Given this list of marker genes PLEKHM3, FBXO36, IGLL1, IL10RB, KLHL26, TMEM213, AGPAT1, RNF166, ACHE, ZNF385C, SLC22A18, TLE6, ZNF865, RPL22L1, RPL7, AJAP1, RAD52, BBX, AQP12A, IGSF9B, SCT, DACH1, ADCY2, MACROH2A1, ATP5MC2, SOBP, ZBTB39, SUB1, HPX, TMEM25, MPPED1, ELAC1, ZBTB8OS, C1QTNF12, CARD6, ZKSCAN5, CLIP4, ZNF260, COL25A1, RAB11FIP1, C8orf33, ALB, ALOX5, MROH2A, NCS1, SCML4, FAHD2A, STAMBP, CARMIL2, STX8, C12orf57, FHIT, DBNDD2, GPBP1L1, SLFN12L, SATB1, TBXA2R, DUSP8, TXNIP, UBN1, KRT81, PTPRF, SYT12, INPP1, PAQR7, ANKZF1, PLXNA3, TRPM6, LMNTD1, SDHC, NSFL1C, CD84 (CD84 molecule), CLCN7, DENND1A, COPZ1, EPS8L3, PTBP1, RPL31, NTRK2, TTLL7, MRPS34, ZNF335, CCNL2, HR, NFE2L1, CAPN13, KCNMA1, SCRT1, RAB37, RAP1GAP, ZNF394, ZNF692, MMEL1, MYBPC3, SERPINA12 (NCBI Gene Id 145264, serpin family A member 12), FAM167B, DLGAP4, KCNJ11, NFE2L3, TCF7, EVL, NUP210L, LPP-AS2, CXorf38, FCGR1A, TMEM151B, CD53, KLF1, TREML2, APOBR, RTL8C, RPL36A, RPS6KA1, SYNE2, NDRG3, GIMAP4, FLOT1, SNRPD1, C9orf50, RGS9, ATG13, RREB1, LAMTOR2, PAQR8, DLX3, ATXN7L3B, RPS14 (ribosomal protein S14), GRAP, HGH1, PHF21A, ALDH1L1, KLK8, TCP11L2, RNF138, TBC1D12, NOBOX, EEF1G (NCBI Gene Id 1937), TMEM204, LTB, AKAP9, CD27, CENATAC, TRIM39, TWNK, AP4S1, CIMIP1, MDM4, GTSF1L, DNASE1L2, ANK1, TCF7L1, SLC2A5 (solute carrier family 2 member 5), NOTCH3, ZSWIM5, RASL11A, MS4A15, FREY1, CLEC4F, IKBKE, ZNF777, RPL18A, GPANK1, NTN5, LRRC61 (NCBI Gene Id 65999), ASPHD1, GREB1, SEZ6L2, CBX7, CACNG5, WFDC5, DDR1, RPL35, ZNF687, ITPR2, LYPD6B, CPNE6, SON (SON DNA and RNA binding protein), AIRN, NCKIPSD, AP5S1, DACT2, TNFRSF1A, GPX7, CLEC16A, ARHGAP28, RTN4R, BAHCC1, CCND2, OLR1, SLC6A3, COX20, MEGF11, RUNDC1, CTRC, PSME1, KRT78, UQCR10, COTL1, ADAM33, here is a description of the gene set: studied in species Homo sapiens Using killer cell lectin-like receptor G1 as a marker to distinguish terminal effector cells from memory precursors, we found that despite their diverse cell fates both subsets possessed remarkably similar gene expression profiles and functioned as equally potent killer cells. However, only the memory precursors were capable of making IL-2 thus defining a novel effector cell that was cytotoxic, expressed granzyme B, and produced inflammatory cytokines in addition to IL-2. This effector population then differentiated into long-lived protective memory T cells capable of self-renewal and rapid re-call responses. Mechanistic studies showed that cells that continued to receive antigenic stimulation during the later stages of infection were more likely to become terminal effectors. Importantly, curtailing antigenic stimulation towards the tail-end of the acute infection enhanced the generation of memory cells. These studies support the decreasing potential model of memory differentiation and show that the duration of antigenic stimulation is a critical regulator of memory formation Human Gene Set: GSE10239_MEMORY_VS_KLRG1HIGH_EFF_CD8_TCELL_UP from publication Sarkar S, Kalia V, Haining WN, Konieczny BT, Subramaniam S, Ahmed R (PMID 18316415) Genes up-regulated in comparison of memory CD8 T cells versus effector CD8 T cells KLRG1 high.